Given this list of marker genes PTPN2, IL2RB, JAK1, IL2RA, JAK3, STAT3, STAT5A, IL2RG, IL2, here is a description of the gene set: Human Gene Set: GOBP_INTERLEUKIN_2_MEDIATED_SIGNALING_PATHWAY studied in species Homo sapiens The series of molecular signals initiated by interleukin-2 binding to its receptor on the surface of a cell, and ending with the regulation of a downstream cellular process, e.g. transcription.